The following is a description of a gene set: studied in species Homo sapiens from publication Nikolsky Y, Sviridov E, Yao J, Dosymbekov D, Ustyansky V, Kaznacheev V, Dezso Z, Mulvey L, Macconaill LE, Winckler W, Serebryiskaya T, Nikolskaya T, Polyak K (PMID 19010930) A single cancer cell contains large numbers of genetic alterations that in combination create the malignant phenotype. However, whether amplified and mutated genes form functional and physical interaction networks that could explain the selection for cells with combined alterations is unknown. To investigate this issue, we characterized copy number alterations in 191 breast tumors using dense single nucleotide polymorphism arrays and identified genes with copy number gain organized into 30 amplicons. Amplicons were distributed unequally throughout the genome. Each amplicon had distinct enrichment pattern in pathways, networks, and molecular functions, but genes within individual amplicons did not form coherent functional units. Genes in amplicons included all major tumorigenic pathways and were highly enriched in breast cancer-causative genes. In contrast, genes with somatic mutations in breast cancer were distributed randomly over the genome, did not represent a functionally cohesive gene set, and were relatively less enriched in breast cancer marker genes. Mutated and gained genes did not show statistically significant overlap but were highly synergistic in populating key tumorigenic pathways including transforming growth factor beta, WNT, fibroblast growth factor, and PIP3 signaling. In general, mutated genes were more frequently upstream of gained genes in transcription regulation signaling than vice versa, suggesting that mutated genes are mainly regulators, whereas gained genes are mostly regulated. ESR1 was the major transcription factor regulating amplified but not mutated genes. Our results support the hypothesis that multiple genetic events, including copy number gains and somatic mutations, are necessary for establishing the malignant cell phenotype. Human Gene Set: NIKOLSKY_BREAST_CANCER_8P12_P11_AMPLICON Genes within amplicon 8p12-p11 identified in a copy number alterations study of 191 breast tumor samples., and this is the list of marker genes: GINS4, PLEKHA2, GOLGA7, ADGRA2, ASH2L, HGSNAT, BAG4, ADRB3, ERLIN2 (NCBI Gene Id 140906), EIF4EBP1, LSM1, ANK1, UNC5D, TACC1, POTEA, CHRNA6, ZMAT4, DDHD2, PLAT, HTRA4, TPT1P8, AP3M2, POLB, IDO1 (NCBI Gene Id 3620), ADAM18, LINC03042, CHRNB3, RNF170, FNTA, FGFR1, SMIM19, PLPBP, ADAM2, TCIM, GOT1L1, IKBKB, PLPP5, IDO2, RAB11FIP1, VDAC3, ZNF703, STAR, SLC20A2, ADAM32, NSD3, SFRP1, KAT6A, GPAT4, POMK, NKX6-3, ADAM9, HOOK3, DKK4, LETM2, THAP1, TM2D2, BRF2